Given this list of marker genes ENSG00000265246, CROCCP3, CDC37, PPP1R42, GABARAPL3, GDPD5, PTPN2, RNA5SP474, RNU6-1340P, CEACAM21, JHY, EIF3F, LINC01485, CXXC1, FAM177A1P1, SH2B3, TRIM15, QSER1, MIR3611, CD160, RPL36, TTC1, ENSG00000243004, LYN, RORA, LYPLA2P1, ENSG00000244137, MIR3529, RN7SKP270, RDH8, YAP1P1, NPAT, DNAI4, HEBP2, MIR3908, PCBP1-AS1, IGSF21, TNFRSF12A, CDCA7P1, ADA, KRT18P45, FMN2, MB (NCBI Gene Id 4151), MAP4K5, H3P10, LIPA, RNU6-847P, LINC01235, CLDN23, FRMD7, GXYLT2, SYCE2, C6orf141, DUS2, FOXP1-AS1, JAZF1-AS1, AP1S3, DHTKD1 (NCBI Gene Id 79141), AURKB, ZEB2P1, MTO1, SLC25A16, CTNNA2, VPS39, SLC6A1 (NCBI Gene Id 6529), RPL32P27, C2CD5-AS1, NEAT1, RNU1-141P, ASS1P5, PRAMEF29P, MAPK6P4, AGMAT, AKAP9 (NCBI Gene Id 10582, A-kinase anchoring protein 9), ANGEL1, ACER3, TRIM55, ENSG00000200235, COQ10A (coenzyme Q10A), CARS1, LINC00929, ARPC1A, TULP2, GIT2, COPS5P1, MIR764, DHPS, MORF4L1P5 (mortality factor 4 like 1 pseudogene 5), SDC4, GALNTL5, GAS8, LINC02390, TOP3B, TPRXL, RFC1, LPGAT1, ALDOA, RB1CC1, BBLNP1, LIM2-AS1, ILDR1, CDK4, MED21, TPM4P1, OR7A17 (NCBI Gene Id 26333), MLST8, WNT8A, RPS27P6, ENSG00000187951, RN7SL93P, NPLOC4, NUCB1-AS1, ZNF675, CYP1B1-AS1, RNU6ATAC36P, BORCS6, SCN3B, CCDC65, RNU4-62P, GTF2I, CFAP299, MIX23, FABP5P3, MCTS1, ITIH3, GC, PPIP5K2, NOL6, KAT8 (lysine acetyltransferase 8), ITGAL-AS1, RND1, ACACA, STX4, SMCR2, TTLL13, HNRNPMP2, PLA2G4C, GLG1, LINC01641, TMEM98, COPS3, ARMH3, TGFB1, PMM1, SRSF8CP, SDAD1P3, MIR3162, C1orf87, ANGPTL6, NAPSA, SPATS2L, TRPM6, RNU6-612P, PVT1, HAPLN2, RNU6-386P, UTP4 (NCBI Gene Id 84916), DDX46 (DEAD-box helicase 46), ZNF863P, TRAV15, ST7L, TNFRSF10B, HSFY1P1, CWC25, SNHG30, SLFN12, SNORD81 (Small nucleolar RNA SNORD81), ESPN, ENSG00000202059, TRPV1, RLIG1P2, SNAP25, H3P44, GDI2, DAGLB, RPL39P18, IFT57P1, ATP9B, CASD1, LTK, VOPP1, LINC00581, DAZAP2, MIR4510, FCHO2, SPEG, RRN3P1, MTND1P14, PPATP1, SDHAF1, TNRC18, LUZP1, PTK2B, RNU6-916P, NFYC (nuclear transcription factor Y subunit gamma), ITGAM, SLC22A11, RNU6-166P, YEATS2, RPL36P2, RNU6-1003P, TCEAL8P1 (NCBI Gene Id 107986036), NLE1, EXOSC2, ELAC2, PLA2G15, MTFMT, ACKR2, CCDC40, SSX7, SPMIP10, SOX9-AS1, IL16, OR1X5P, FES, CMKLR2-AS, GLRX5P2, ENSG00000233242, OR1X1P, PFAS, here is a description of the gene set: Human Gene Set: ZNF781_TARGET_GENES Genes containing one or more binding sites for (ZNF781) in their promoter regions (TSS -1000,+100 bp) as identified by GTRD version 20.06 ChIP-seq harmonization. studied in species Homo sapiens from publication Yevshin I, Sharipov R, Kolmykov S, Kondrakhin Y, Kolpakov F (PMID 30445619)